Given this list of marker genes Sumo1, H2bc1, Trp53bp1, Mapk8, Babam1, H4c3, Smarca5, H2bc7, H4c9, H2bc11, H2bc12, Bard1, Eya3, Mdc1, H4c6, Kat5, H4c17, Ppp5c, H2bc15, Ubb, H2bc3, H4c1, Rnf168, Chek2, Apbb1, H4c11, Brcc3, Mre11a, Pias4, H2bc22, H2bc27, Trp53, H4c14, Brca1, H4c18, Rps27a, H4c12, H4c4 (H4 clustered histone 4), H2bc8, Ube2n, Nbn, H4c8 (NCBI Gene Id 69386), H2bc9, Eya1 (EYA transcriptional coactivator and phosphatase 1), H4c2, H2ax, H2bc13, here is a description of the gene set: species: Mus musculus Reactome Pathway: Recruitment and ATM-mediated phosphorylation of repair and signaling proteins at DNA double strand breaks electronically inferred by orthology from the curated human pathway part of: DNA Double Strand Break Response This event has been computationally inferred from an event that has been demonstrated in another species.<p>The inference is based on the homology mapping from PANTHER. Briefly, reactions for which all involved PhysicalEntities (in input, output and catalyst) have a mapped orthologue/paralogue (for complexes at least 75% of components must have a mapping) are inferred to the other species.